Given this list of marker genes Bsnd, Fasl, Tbxas1, Kcne3, Stk39, Slc12a8, Slc12a2, Slc12a5, Cacna1a, Slc12a1, Slc12a9, Umod, Ckb, Stc1, Cps1, Car12, Abcc2, Kcnq1, Ptk2, Slc12a4, Wnk4, Slc12a3, Slc12a7, Otc, Wnk1, Atp6v1b1, Spp1, Slc12a6, here is a description of the gene set: Mouse Gene Set: GOBP_MONOATOMIC_ANION_HOMEOSTASIS species: Mus musculus Any process involved in the maintenance of an internal steady state of monoatomic anions within an organism or cell. Monatomic anions (also called simple anions) are anions consisting of exactly one atom.